The following is a description of a gene set: studied in species Homo sapiens Neighborhood of SKP1A Human Gene Set: MORF_SKP1A Neighborhood of SKP1A S-phase kinase-associated protein 1A (p19A) in the MORF expression compendium, and this is the list of marker genes: DRG1, ARF3, LYPLA1, DDX49, URM1 (NCBI Gene Id 81605), CALM3, AP2S1, COX7A2L (cytochrome c oxidase subunit 7A2 like), PSMB2, AP2M1, COX5A, SF3B2, GABARAPL2, PCLAF, TRIM28, SNRPA1, SNRNP200, NDUFA2, IST1, ATP6AP1, UBR5, H2AZ1, GDE1, VPS52, POLE3, COPS5, CTCF, HNRNPC, KIF2A, PPP1R7, PUF60, SRP19, COX7C, HSPA9, CBX3, WBP2, DNPEP, SRP9, U2AF1, RBMX, SET, PSMD8, BANF1, UBE2L3, PPP1CA, DAP, RAD23A, PPM1G, CLTA, LSM3, HNRNPUL1, NDUFS3, NDUFA5, EIF3E, COX6B1, SMG7, SSR2, HADHB, HMGN1, RAB14, CYC1, KXD1, SUMO3, TLK1, YY1, NEDD8, VCP, STARD7, CDC123, CNIH1, HNRNPA3P1, SYPL1, NDUFS1, CNBP, EIF3C, NACA, UBE4A, PRMT1, PSMC2, MRPL9, PSMC1, TMEM183A, EEF1D (eukaryotic translation elongation factor 1 delta), PPP2R2A, HSBP1, ATP5MF, MAML1, MTDH, TAF11, RPL36AL, UQCRFS1, ANP32B, PSMD7, NDUFV1, MYL11, NONO, PSMA3, EOLA1, SNRPG, BTF3, SEPTIN2, TMED2, TBCA, CFDP1, CSNK2B, RAD21, ATP5F1C, SMARCD2, HAT1, SLC25A3, SNRPE, SRP14, BUD31, CANX, RER1, PRRC2C, SRSF3, ATP5PD, PPP2R1A, EIF4H, COX6C, RALY, PSMB4, PPP6C, RAC1, YME1L1, NDUFA1, NSDHL, HNRNPAB, SNX3 (sorting nexin 3), SKP1, SEM1, SUMO1, AZIN1, COX4I1, COA1, COX11, HDGF, KHDRBS1, LSS, SRSF9, ATP5PF, PSMA2, UBE2N, YWHAE, MAD2L1BP, YWHAZ, VTI1B, ETFA, CCT2, EBAG9, ELOC, MDH1, MORF4L2, HARS2, GGCT, SOD1, YWHAB (tyrosine 3-monooxygenase/tryptophan 5-monooxygenase activation protein beta), DEK, BZW1, MBD4, JTB, COIL, COX6A1, UTP18, RNF6, UQCRB, COPB1, KPNA2, WIPI2, PDCD6, BAG5, HGS, RAD23B, TIAL1, COX7B, KARS1, RHEB, EIF4E2, PSMB1, COPE, TMBIM6, BCAP31, PSMD9, RAB5A, UBA2, UBA1, HSP90AA1, RAN, PARK7, GLOD4, UBAP2L, ATP6V0C, PDAP1, EIF4A1, SUMO2, DCTN2, NDUFV2, ILF3, TRAPPC3, PSMC6, SEC13, ENSA, GMFB